Given this list of marker genes Ypel4, Spi1, Glul, Zfp36l1, Prmt1, Hoxa5, Stat5a, P4htm, Stat5b, Nckap1l, Ldb1, Stat3, Brd1, Med1, Hspa1b, Fam210b, Acvr2a, Gata1, Zfp36, Kat7, Hif1a, Kdm1a (NCBI Gene Id 99982), Ankrd54, Inpp5d, Ets1, Id2, Klf13, Isg15, B2m, Gata2, Zfpm1, Senp1, Gfi1b, Cdk6, Inhba, Rbfox2, Mafb, Prkdc, Acvr1b, Lmo2, Smap1, Mapk14, Mir125a, Foxo3 (NCBI Gene Id 97633), Hspa9, Tal1, Setd1a, Lyn, Stat1, Hmgb2, Abcb10, here is a description of the gene set: Any process that modulates the frequency, rate or extent of erythrocyte differentiation. species: Mus musculus Mouse Gene Set: GOBP_REGULATION_OF_ERYTHROCYTE_DIFFERENTIATION